Given this list of marker genes C1GALT1C1, SLC6A16, TMEM131, MRPL51, CCDC92, FBXL3, FYB1, TAB2, AKT3, PCM1, ERBIN, TECPR1, GNAQ, RIPK3, RAB2B, RNF170, PBX3, MTIF3, RNF34, MAN2B2, ILRUN, SLC35A5, CCNI, PDCD10, RABIF, HMGB2, SEC24B, MICU2, CD46, GIMAP8, ARF3, INTS4, GPR107, DNAJC13, CASD1 (NCBI Gene Id 85885), STX8, MLLT10, FAM219A, TFDP1, MAPK9, PI4KB, CEP135, PARVG, FNTA, CDC7, HP1BP3, PTBP3, FBXO9, OARD1, SP100, GMPR2, SSX2IP, LMBRD2, BRD4, MAD1L1, MSS51, DDX17, CDK2, DDHD2, PDZD11 (NCBI Gene Id 51248), ESYT1, CCDC91, PURA, KANSL1, CYTH1, ACOT13, PCBP1-AS1, TNFAIP8L1, DCLRE1A (DNA cross-link repair 1A), ARAP2, TNFRSF14, ABR, AP2B1, COPB1, PRDM10, ZNF449, PAQR8, SFT2D1 (NCBI Gene Id 113402), KIAA0753, GLE1, BAG6, TPM3, ADH5, PPP1R7, TUBA4A, TXNDC12, TAPBPL, MBP, EPC2, PHF23 (PHD finger protein 23), IFNAR1, TWF2, CNOT10, ZMYND11 (NCBI Gene Id 10771), ZCCHC9, SMURF2, SSH2, EPC1, ZDHHC13, BPTF, UTRN, MYL12A, DENND6A, CORO7, DAZAP2, MOB3A, SNX3, SLTM, VPS26C, FDPS, KCTD21, KAT6B, PSEN1, GIMAP1 (NCBI Gene Id 170575), SLFN12, METTL3, TNKS, ZNF318, THAP1, MTRF1, SEC11A, UHMK1, METTL4, NSL1, SQSTM1, RC3H2, SPG7, CSK, PTPRCAP (protein tyrosine phosphatase receptor type C associated protein), ZNF688, NDUFAF1, AGO4, TNFRSF14-AS1, MAD2L2, SKIC3, PCNP, NDUFC1, VAV1, MPC2, UBA3, SUSD1, IPP, RBM41, ZC3HAV1L, PRXL2B, SLC31A2 (NCBI Gene Id 1318), CHIC1, VPS45, GIT2, PHTF1, CASP8, ELP4, TASOR, MED13, GPR15, TRAC, RNASEK, CHD6, STRADA, OSBPL8, ZNF512B, AGGF1, KLHL5 (NCBI Gene Id 54163), NKTR, FBXO8, ZNRF2, SLC25A25-AS1, GIMAP7, SMC3, CFL1, LCP1, MAN1A2, FAS, MRPL14, ZFYVE26, RB1, RGL4, NDE1, HAUS3, ZNF407, ARRB2, ARID4A, TUBA1A, DPY30 (dpy-30 histone methyltransferase complex regulatory subunit), CCNDBP1, WAC, ARHGEF6, CIZ1, PDE3B, ACAP2, N4BP2L2, ASCC3, SLC36A1, IRF7, ALG10B, ATG2A, RESF1, here is a description of the gene set: Human Gene Set: GSE32533_WT_VS_MIR17_KO_ACT_CD4_TCELL_DN from publication Jiang S, Li C, Olive V, Lykken E, Feng F, Sevilla J, Wan Y, He L, Li QJ (PMID 21972292) Genes down-regulated in activated CD4 T cells: wildtype versus MIR17 knockout. miR-17 from the miR-17-92 cluster regulate activation-induced cell death in T cells and modulate inducible regulatory T cell differentiation. We used microarrays to detail the global program of gene expression modulated by miR-17 and aim to identify the potential targets of miR-17. species: Homo sapiens